The following is a description of a gene set: Genes predicted to be targets of miRBase v22 microRNA hsa-miR-208a-3p in miRDB v6.0 with MirTarget v4 prediction scores > 80 (high confidence targets). studied in species Homo sapiens Human Gene Set: MIR208A_3P from publication Chen Y, Wang X (PMID 31504780), and this is the list of marker genes: PTBP2, RIMS1, CNOT9, ETS1, PDCD4, MCU (NCBI Gene Id 90550), SLC6A13, REEP1, UBE2V2, CREBZF, EYA4, STC1, CNKSR2, GOLGA6L4, MFSD14A, COG5, HP1BP3 (heterochromatin protein 1 binding protein 3), SNX2, TSPAN12, RAB5C, OSBPL1A (oxysterol binding protein like 1A), LNPK, SOX6, LRRTM1, MED13, VPS13C, MTF2, HEMGN (hemogen), CSNK2A2, NLK, SEC14L1, RECQL, NSMCE1, OMG, GOLGA6L9, SLC30A4, KIF13B, YBX1, UBE2V1, RNF145, KDM7A, FOXN2, FNIP1, UBE2J1